Given this list of marker genes F9, F10, F8, here is a description of the gene set: Reactome Pathway: Defective factor IX causes thrombophilia In healthy individuals factor IXa (FIXa), in a complex with factor VIIIa on the surfaces of activated platelets, catalyzes the formation of activated factor X with high efficiency. A substitution of leucine for arginine at residue 384 in FIX (FIX R384L, also know as FIX Padua) is a gain-of-function mutation that resulted in elevated FIX clotting activity in a patient with venous thrombosis (Simioni P et al. 2009). species: Homo sapiens part of: Defects of Coagulation cascade